Given this list of marker genes Enoph1, Mat1a, Apip, Bhmt1b, Mthfd2l, Mtr, Mthfd1, Gnmt, Mtap, Bhmt2, Mri1, Mthfr, Adi1 (NCBI Gene Id 217448), Mtrr, Bhmt, here is a description of the gene set: species: Mus musculus Mouse Gene Set: GOBP_METHIONINE_METABOLIC_PROCESS The chemical reactions and pathways involving methionine (2-amino-4-(methylthio)butanoic acid), a sulfur-containing, essential amino acid found in peptide linkage in proteins.